The following is a description of a gene set: Cytokines mediate cell-cell communication in the immune system and represent important therapeutic targets. A myriad of studies have highlighted their central role in immune function, yet we lack a global view of the cellular responses of each immune cell type to each cytokine. To address this gap, the authors created the Immune Dictionary, a compendium of single-cell transcriptomic profiles of more than 17 immune cell types in response to each of 86 cytokines (>1,400 cytokine-cell type combinations) in mouse lymph nodes in vivo. A cytokine-centric view of the dictionary revealed that most cytokines induce highly cell-type-specific responses. For example, the inflammatory cytokine interleukin-1β induces distinct gene programmes in almost every cell type. A cell-type-centric view of the dictionary identified more than 66 cytokine-driven cellular polarization states across immune cell types, including previously uncharacterized states such as an interleukin-18-induced polyfunctional natural killer cell state. from publication Cui A, Huang T, Li S, Ma A, Pérez JL, Sander C, Keskin DB, Wu CJ, Fraenkel E, Hacohen N (PMID 38057668) Genes positively differentially expressed in cell type: γδ T cell upon treatment with cytokine: IL-1β in mouse lymph nodes in vivo. Mouse Gene Set: CUI_T_CELL_GD_IL1B_RESPONSE_UP studied in species Mus musculus, and this is the list of marker genes: Tmed5, Tomm5, Cct3, Rrbp1, Isy1 (NCBI Gene Id 76060), Ctsz, Rcl1, Abce1, Ddx56, Pcbp1, Ptma, Bcl2a1d, Apobec3, Mrpl20, Nhp2, Npm1, Tkt, Tufm, Ctu2, Kars1, Impdh2, Crtc2, Lman2, Pcyt1a, Mt1, Pou2f2, Laptm4b, Gart (phosphoribosylglycinamide formyltransferase), Ltv1, Psma2, Nars1, G3bp1, Ly6a, Gar1, Eef1e1, Cct4, Socs3, Dpp8, Gzmc, Cycs, Dnajb11, Psen2, Eif3d, Hnrnpa3, Eif1, Hsp90ab1, Lyar, Gsto1, Nifk, Timm8a1, Tnfaip8, Ehd1, Tnfrsf9, H2-Aa, Uck2, Ppa1, Luc7l, Slc25a51, Llph, Ybx3, Ddost (dolichyl-di-phosphooligosaccharide-protein glycotransferase), Sar1a, Wdr43, Arap2, Kcnq1ot1, U2af1, Nop10, Sdhaf1, Ahr, Marcks, Vmp1, Hint1, Cdv3, Bcap29, Helz2, Atp5f1d, Il2ra, Utp11, Tnfrsf18, Calr, Phb1, Traf1, Gcsh, Ttc39b, Ebna1bp2, Hspe1 (heat shock protein 1 (chaperonin 10)), Kpnb1, Tyrobp, Hspa8, Apoe, Anp32b, Stx11, Kdm2b, Cox5a, Rsl24d1, Cebpz, Cct5, Pdap1, Slco3a1, Snrpd2, Serp1, Mydgf, St6galnac4, Atp1a1, Ruvbl1, Psme1, Ndufa12 (NADH:ubiquinone oxidoreductase subunit A12), Tuba1b, Eif1ax, Nap1l1, Ilf2, Aprt, Ostc, Srsf3 (serine and arginine-rich splicing factor 3), Crem, Eif5a, Ftsj3, Btf3, Jak2, Cdc37, Relb, Sec14l1, Emd, Cct8, Aebp2, Hacd3, Psmb7, Ddx1, Nop58, Ipo4, Ahcyl2, Psme2, Timm13, Tcerg1, Rbpj, Pdcd1lg2, Il4i1, Mapkapk2, Abcc1, Larp1, Herpud1, Celf2, Fabp5, Magoh, Mybbp1a, Mtap, Alkbh6, Ewsr1, Abcf2, Snx18, Iars1, Cyba, Serinc3, Ubqln4, Lrrc59, Zeb2, Heatr3, H2-K1, Eif3b, Mrps6, Shmt2, Mettl1, Slc19a1, Txn2, Wdr83os, Cacybp, Atic, Polr1d, Sec61b, Banf1, Ssr2, Emc6, Hnrnpab, Lars1, Atp5f1b, Adam8, Cxcl13, Eef1d, Ern1, Batf, Psmd11, Prpf31, Tspan3, Cpsf6, Myo1g, Ran, Nop16, Pdcd1, Elp5, Eprs1, Ikbke, Prmt1, Set, Slc1a5, Snrpb, Hdgf, Dcun1d5, Psme3, Mrpl17, Tars1, Mrpl19 (mitochondrial ribosomal protein L19), Strap (serine/threonine kinase receptor associated protein), Rars1, Nfkb2, Glrx3, Creld2, Ifitm2, Phf5a, Tmem154 (transmembrane protein 154), Rrp1b, Eif2s2, Manf, Smyd2, Ankrd39, Rrs1, Kmt5a, Noc2l, Npm3, Eif3c, Rangrf, Jade2, Bzw2, Azin1, Slc25a5 (solute carrier family 25 (mitochondrial carrier, adenine nucleotide translocator), member 5), Naa15, Imp3 (IMP3, U3 small nucleolar ribonucleoprotein), Wnk1, Prdx6, Tubb4b, Nomo1, Pabpc4, Timm9, Mthfd1, Denr, Mars1, Tomm20, Snu13, Lpcat1, Rpn1, Psmb6, Ndufaf4 (NADH:ubiquinone oxidoreductase complex assembly factor 4), Eif3i, Uqcrq, Trmt1, Ddx39a, Fam162a, Wdr18, Sytl3, Snrpd1, Rrp9, Sumo2 (small ubiquitin-like modifier 2), Rcc2, Mdn1, Tfrc, Alkbh1, Pgam1, Nme1, Caprin1, Etf1, Nrip1 (NCBI Gene Id 77882), Cytip, Gadd45b, Nop2, Snrpf, Gnl3, Hyou1, Cks2, Eif2s1, Eif3g, Serbp1, Ppid, Cnbp, Ybx1, Eef1g, Ccdc86, Pum3, Atp5mk, Hmgn3, Il2rb, Cdc34, Hprt1, Dad1, Ranbp2, Hsp90b1, Phb2, Srsf2, Pabpc1, Immt, Syngr2, Cd72 (CD72 antigen), Ppp1r14c, Hspa9, Trp53, Nip7, Nudcd2 (NCBI Gene Id 67191), Ccdc184, Dennd4a, Psmd12, Csf2, Chchd2, Clptm1l, Utp3, Bax, Gpr18, Srm (NCBI Gene Id 99964), Heatr1, Nop56, Tlr1, Vcp, Bcl2a1b (NCBI Gene Id 12045), Pgk1, Ywhae, Zc3h15, Cd82, Mir155hg, Srsf7, Naa50, Hsp90aa1, Nipa2, Larp7, Gramd4 (NCBI Gene Id 223752), Prr29, Lyz1, Niban1, Polr2c, Tmed9, Prpf40a, Ldha, Ddb1, Atp5mc3 (NCBI Gene Id 277484), Ndufaf8, Pwp1, Canx, Ywhaq, Stip1, Hnrnpd, Mrpl52, Nup62, Slc35b1, Zmiz2, Cd74, Lyz2, Ranbp1 (NCBI Gene Id 19385), Kri1, Rsl1d1, Hars1, Tpi1, Cluh, Tmed2, Ptp4a2, Prrc2a, Rel, Dennd5a, Tspan13, Mrpl15, Hif1a, Morf4l2 (mortality factor 4 like 2), Slc15a3, Lsm12, Eif1a, Fam110a, Tomm40, Snrpe, Lad1, Rbm8a, Bop1, C1qbp, Sdf2l1, Znrd2, Tcp1, Ppan, Lap3, Stx6, Thap12, Hsd17b12, Ccr4 (C-C motif chemokine receptor 4), Ythdf2, Rpf2 (NCBI Gene Id 67239), Lsm2, Pebp1, Macir, Tesk1 (NCBI Gene Id 21754), Il4ra, Clic4, Pa2g4, Npnt, Grpel1, Dgat1, Eif6, Il22, Gzmb, Bcl2l1, Naga, Zfp106, Bcl3, Ncl, Apex1, Samsn1, Sfxn1, Dctpp1, Hdlbp, Nfkb1, Pals2, Smox (NCBI Gene Id 319808), Calca (calcitonin/calcitonin-related polypeptide, alpha), Uchl5, Atad3a, Nrros, Slc25a39, Eif4g1, Snrnp70, Odc1, Rora, Rrp15, Igfbp4, Serpina3g, Ppp1r14b, Ptges3, Birc3, Mthfd1l, Pim2, Ufm1, Arfrp1, Chchd4, Tsr1, Syncrip, Stat3, Mif (macrophage migration inhibitory factor (glycosylation-inhibiting factor)), Mat2a, Sdc4, H2-Ab1, Tma16, Utp14a, Pon2, Eif5b, Psma6, Irf5, Hspa4, Prdx1, Nolc1, Txnl4a, Pitrm1, Nsun2, Ptprs, Fbl, Icam1, Pno1, Grwd1, Nadk, Taf10 (NCBI Gene Id 24075), Polr1f, Erh, Ipo5, Stat5a, Mrto4, Tmem147, St13, Mrpl12, Mthfd2, Tex2 (testis expressed gene 2), Bsg, Ivns1abp, Txndc17, Ssr4, Zc3h12a, Eif2s3x, Ptpn22, Mllt6, Ddx21, Srgn, Aen, Pdia6 (NCBI Gene Id 97794), Cish, Ddx27, Eif4g2, Rab8b, Abcf1, Srsf4, Eif4e, Tm9sf2, Slc25a3, Snrpa1, Hspa5, Psmd1, M6pr, Gtpbp4, Eif4a1, Nom1, Marcksl1, Bzw1, Serpinb6b, Fcf1, Sf3b3, Rbm3, Orai1, Ncoa7, Slc30a5, Serpinb9, Ppme1, Furin, Hspd1, Dkc1, Rilpl2, Cd63, Cct2, Mapk1ip1l, Pus7, Atp5mc1, Smyd5, Larp4, Fam107b, Nfkbia, Bhlhe40, Cd83, Timm10, Ifrd2, Vars1, Eif3a, Phip, Zfp593